Given this list of marker genes INSRR, CHP1, KCNK4, HYAL1, GPLD1, ASIC1, HVCN1, SCNN1A, SCNN1B, GPR68, PKD2L1, GPR65, GNA11, RAB11FIP5, MCOLN1, KCNK1 (NCBI Gene Id 3775), KCNK9, SCNN1G, RAB11B, SCNN1D, TRPV1, SLC9A1, KCNK3, ASIC2 (NCBI Gene Id 729787), KCNK18, PKD1L3, GPR4, here is a description of the gene set: Human Gene Set: GOBP_CELLULAR_RESPONSE_TO_PH Any process that results in a change in state or activity of a cell (in terms of movement, secretion, enzyme production, gene expression, etc.) as a result of a pH stimulus. pH is a measure of the acidity or basicity of an aqueous solution. studied in species Homo sapiens